The following is a description of a gene set: studied in species Homo sapiens Reactome Pathway: Inhibition of nitric oxide production Phagocytes produce nitric oxide to damage interned bacteria before fusion of the phagosome with lysosomes. While Mtb has several pathways to neutralize NO it also attempts to block the host enzymes used for NO production. part of: Suppression of phagosomal maturation, and this is the list of marker genes: NOS2, KPNB1, KPNA1, PPE2